Given this list of marker genes NUS1, MIR17, MIR185, TMEM97, PCSK9, ANXA2, ARV1, ABCA12, MIR27B, ANXA2P2, LDLRAP1, SCP2, ABCA2, here is a description of the gene set: Any process that modulates the frequency, rate or extent of the directed movement of lipids within cells. studied in species Homo sapiens Human Gene Set: GOBP_REGULATION_OF_INTRACELLULAR_LIPID_TRANSPORT